The following is a description of a gene set: Reactome Pathway: YAP1- and WWTR1 (TAZ)-stimulated gene expression species: Mus musculus This event has been computationally inferred from an event that has been demonstrated in another species.<p>The inference is based on the homology mapping from PANTHER. Briefly, reactions for which all involved PhysicalEntities (in input, output and catalyst) have a mapped orthologue/paralogue (for complexes at least 75% of components must have a mapping) are inferred to the other species. part of: Generic Transcription Pathway electronically inferred by orthology from the curated human pathway, and this is the list of marker genes: Yap1, Tead2, Tead4, Wwtr1 (NCBI Gene Id 97064, WW domain containing transcription regulator 1), Tbx5